The following is a description of a gene set: studied in species Mus musculus Mouse Gene Set: IKEDA_MIR1_TARGETS_DN Calcium signaling is a central regulator of cardiomyocyte growth and function. Calmodulin is a critical mediator of calcium signals. Because the amount of calmodulin within cardiomyocytes is limiting, the precise control of calmodulin expression is important for the regulation of calcium signaling. In this study, we show for the first time that calmodulin levels are regulated posttranscriptionally in heart failure. The cardiomyocyte-restricted microRNA miR-1 inhibited the translation of calmodulin-encoding mRNAs via highly conserved target sites within their 3' untranslated regions. In keeping with its effect on calmodulin expression, miR-1 downregulated calcium-calmodulin signaling through calcineurin to NFAT. miR-1 also negatively regulated the expression of Mef2a and Gata4, key transcription factors that mediate calcium-dependent changes in gene expression. Consistent with the downregulation of these hypertrophy-associated genes, miR-1 attenuated cardiomyocyte hypertrophy in cultured neonatal rat cardiomyocytes and in the intact adult heart. Our data indicate that miR-1 regulates cardiomyocyte growth responses by negatively regulating the calcium signaling components calmodulin, Mef2a, and Gata4. Genes down-regulated in hypertrophic hearts (due to expression of constitutively active form of PPP3CA) and predicted to be targets of miR-1 microRNA. from publication Ikeda S, He A, Kong SW, Lu J, Bejar R, Bodyak N, Lee KH, Ma Q, Kang PM, Golub TR, Pu WT (PMID 19188439), and this is the list of marker genes: Hspd1, Rbfox1, Stk39, Mtss1, Clcn3, Smim36, Eif4e